The following is a description of a gene set: Any process that modulates the rate, frequency, or extent of prostate gland branching, the process in which the branching structure of the prostate gland is generated and organized. A branch is a division or offshoot from a main stem. species: Mus musculus Mouse Gene Set: GOBP_REGULATION_OF_BRANCHING_INVOLVED_IN_PROSTATE_GLAND_MORPHOGENESIS, and this is the list of marker genes: Sfrp1, Hoxd13, Rxra, Esr1, Bmp4, Bmp7